Given this list of marker genes HLA-H, HLA-A, B2M, HLA-G, HLA-C, MR1, HFE, HLA-E, HLA-F, HLA-B, here is a description of the gene set: species: Homo sapiens A transmembrane protein complex composed of a MHC class I alpha chain and an invariant beta2-microglobin chain, and with or without a bound peptide antigen. Class I here refers to classical class I molecules. Human Gene Set: GOCC_MHC_CLASS_I_PROTEIN_COMPLEX